Given this list of marker genes URI1, MBNL3, MRPL51, PARN, FBXO21, IL1R1, RGS18, WIPI1 (WD repeat domain, phosphoinositide interacting 1), CPNE3, CNIH4, FBXW8, POU6F2, NEDD1, ATP5PB, DARS1 (NCBI Gene Id 1615), PPA2, CDK2AP1, HPS3, FAM199X, KLHL4, ASB18, WDR12, GPR179, XPO1, BLOC1S6, RNASEL, CRAT, MRPS33, POGLUT1, PPP3CB, AQR (aquarius intron-binding spliceosomal factor), DCP2 (NCBI Gene Id 167227), TMX4, MRS2, OSGEPL1, USP46, EAPP, BLVRB, LCOR, SRI, NUDT16, KLHDC8B, ERAP1, TRAM1, GPSM2, CUL4A, PPP1R7, TMEM179 (NCBI Gene Id 388021), SIGMAR1, DPAGT1, ALG8 (ALG8 alpha-1,3-glucosyltransferase), ANKRD40, TMCO1, PGP, ARHGAP19, ALDH2, BTD, FIBP, RAB9B, AGTRAP, CMC1, SLC22A20P, MCCC2, GPAT2, CRYGS, OTUB2, FPGS, CASP8, POLDIP2, DCAF7, H2AC6, FUT4, SESN1, ANAPC4, IL12A, ELMOD2, TMEM209, DIRAS2, BAZ1B (bromodomain adjacent to zinc finger domain 1B), ASB8, MCRIP2, WARS1 (tryptophanyl-tRNA synthetase 1), ARMC7, STX18, KCNK12, COG4, NDUFB4, PCYOX1, SUFU, APIP, PARD6B, KLHL36, NME4, NUDT7, TGDS, CD300LD (NCBI Gene Id 441800), ARHGAP11A, ADCY6, LTA4H, GPR52, ALKBH4, CIAO1, DGCR8, LHX1, LCORL, XRCC5, PDCD6IP, PHB2, ANAPC1, MAP3K13, TYW1, PAXIP1, CLYBL, IL20RA, CKAP5, MRPL35 (mitochondrial ribosomal protein L35), FGFR1OP2, LYPLA1, OGFOD1, HS6ST1, CEP76, GDF3, MIR382, GPAA1, QDPR, PRR5, LRIG2, GTF3C5, POLE2, MYL4, ARHGAP1, SACM1L, FBXO4, HTR1D, SNCA, GALNT4, GNS, MRPL1, CLEC10A, TBC1D31, WDSUB1, TRAT1, DEXI, PARS2, PGD, PELP1, S100A1, IMPA1, JPH1, RWDD2B, DNA2, HDGF, SLC35A5, BET1, GGH (NCBI Gene Id 8836), IRF2BP1, here is a description of the gene set: Borrelia burgdorferi, the agent of Lyme disease, promotes pro-inflammatory changes in endothelium that lead to the recruitment of leukocytes. The host immune response to infection results in increased levels of IFN-gamma in the serum and lesions of Lyme disease patients that correlate with greater severity of disease. Therefore, the effect of IFN-gamma on the gene expression profile of primary human endothelial cells exposed to B. burgdorferi was determined. B. burgdorferi and IFN-gamma synergistically augmented the expression of genes, seven of which encode chemokines. Six of these (CCL7, CCL8, CX3CL1, CXCL9, CXCL10, and CXCL11) attract T lymphocytes, and one (CXCL2) is specific for neutrophils. Synergistic production of the attractants for T cells was confirmed at the protein level. IL-1beta, TNF-alpha, and LPS also cooperated with IFN-gamma to induce synergistic production of CXCL10 by endothelium, indicating that IFN-gamma potentiates inflammation in concert with a variety of mediators. An in vitro model of the blood vessel wall revealed that an increased number of human T lymphocytes traversed endothelium exposed to B. burgdorferi and IFN-gamma, as compared to unstimulated endothelial monolayers. In contrast, addition of IFN-gamma diminished the migration of neutrophils across B. burgdorferi-activated endothelium. IFN-gamma thus alters gene expression by endothelium exposed to B. burgdorferi in a manner that promotes recruitment of T cells and suppresses that of neutrophils. This modulation may facilitate the development of chronic inflammatory lesions in Lyme disease. species: Homo sapiens Genes up-regulated in endothelial cells: untreated versus exposed to E. burgdoferi. Human Gene Set: GSE6092_CTRL_VS_BORRELIA_BIRGDOFERI_INF_ENDOTHELIAL_CELL_UP from publication Dame TM, Orenzoff BL, Palmer LE, Furie MB (PMID 17202382)